Given this list of marker genes Nrp1, Myh10, Cttn, Shtn1, P2ry12, Ntn1, Nck1, Abl2, here is a description of the gene set: species: Mus musculus Mouse Gene Set: GOBP_SUBSTRATE_DEPENDENT_CELL_MIGRATION_CELL_EXTENSION The formation of a cell surface protrusion, such as a lamellipodium or filopodium, at the leading edge of a migrating cell.